Given this list of marker genes ZP1, INSR, AURKA, ACVR1B, C9orf78, ASPM, GPR149, NOX5, TMPRSS12, OOEP, ZP3, RBM46, KNL1 (kinetochore scaffold 1), SPINK1, TAC4, WEE2, ADA, CFAP69, GJA1, TCP11X1, INHBB, CDC25A, ZWINT, LHFPL2, FZR1, OVGP1, WNT5A, MAEL, CDC26, TPST2, STK11, PLB1, FBXO5, SFRP1, SYDE1, SYCP2, LFNG, CDC27, TACR1, ANAPC10, PRSS37, SOD1, MIR16-1, SRY, ANAPC2, NANOS2, MIR15B, OXT, MOS, SERPINF1, TEX11, PLAT, ANKRD31, EDNRB, MYH9, SOX9, UMODL1, ASTL, B4GALT1, SHH, ANAPC4, TAC3, VEGFA, PIWIL2, FAM170B (NCBI Gene Id 399567), KIF9, P2RY1, METTL3 (NCBI Gene Id 95719), KIT, RPS6KA2, PSMA8, IRGC, CCDC87, TIMP1, YTHDF2, USP17L2, NPR2, DEFB1, RNASE10, ACVR1C, CCR6, BMP7, PLCB1, INTS13, AGO2, ANAPC7, SHB, BCL2L1, OVOL1, RAD51AP1, NLRP5, ABCB1, INHBA, CDC25B, CDC16, DAZL, TACR2, PRDM9, CACNA1H, MEIOC, HOXD13, CNTD1, PDE3A, PLA2G10, CTNNB1, TAC1, WT1, ANAPC16, CFAP206, SPATA22, CDC25C, PRDM14, MSX2, SYCE3, FBXO43, CHFR, BAX, PAEP, NPM2, WNT4, C1QBP, HYAL3, ZP2, HDAC2, EAF2, MSX1 (msh homeobox 1), RETN, YTHDC2, AR, STK4, CLXN, BNC1, GPR3, ANAPC13, TACR3, TRIP13, LIF, ANAPC5, IQCF1, CALR, SERPINA10, SNAI1, PTGDR2, NR5A1, HORMAD1, DDB1, CDC20, TEX101, UNC5C, YBX3, PRDX4, ESR1 (estrogen receptor 1), GCM1, NKX3-1, APELA, ADAM7, SEMG1, MAPK15, STK3, SPINK13, DMRT1 (NCBI Gene Id 82031), GDF9, CRISP1, WDR77, PGAM4, SEMG2, SIRT2, UBE2B, ANAPC15, NUPR1, SULF1, HVCN1, GLRA1, IHO1, TTK, DUSP1, ANAPC11, RAD1, CITED2 (Cbp/p300 interacting transactivator with Glu/Asp rich carboxy-terminal domain 2), CIB1, IGF1, STRA8, EPPIN, PKDREJ, CDC23, ELF5 (E74 like ETS transcription factor 5), NODAL, HPGDS, ANAPC1, TPPP2, ZP4, CDKN1B, BMP4, PDIK1L, DHX37, ARHGDIB, PKMYT1, ZFPM2, PPP2R1A, TCP11X2, STK35, SMURF2, TCP11, MEIOSIN, PTGDS, NPPC, here is a description of the gene set: studied in species Homo sapiens Human Gene Set: GOBP_REGULATION_OF_REPRODUCTIVE_PROCESS Any process that modulates the frequency, rate or extent of reproductive process.